Given this list of marker genes Hgd, Fah, Gstz1, Tat, Hpd, here is a description of the gene set: studied in species Mus musculus part of: Phenylalanine and tyrosine metabolism electronically inferred by orthology from the curated human pathway Reactome Pathway: Tyrosine catabolism This event has been computationally inferred from an event that has been demonstrated in another species.<p>The inference is based on the homology mapping from PANTHER. Briefly, reactions for which all involved PhysicalEntities (in input, output and catalyst) have a mapped orthologue/paralogue (for complexes at least 75% of components must have a mapping) are inferred to the other species.